The following is a description of a gene set: Human Gene Set: GOBP_CELL_CYCLE_G1_S_PHASE_TRANSITION studied in species Homo sapiens The cell cycle process by which a cell in G1 phase commits to S phase., and this is the list of marker genes: BTN2A2, PBRM1, RPS6KB1, CDKN2C, MLF1, TFDP3, ZNF324, DDRGK1, CUL2, SLFN11, ATP2B4, TRIM39 (NCBI Gene Id 56658), MYO16, RGCC, MIR372, CCNI2, PAGR1, MIR26A1, GPR132, ACVR1B, CUL4A, MTBP, CDKN2B, MIR15B, GSPT1, CTDSP2, MYB, TRIAP1 (TP53 regulated inhibitor of apoptosis 1), PLK2, CUL4B, FBXO7, MIR29A, INO80, MIR208A, PSME3, CCND1, RDX, EIF4EBP1, LSM11, CCND3, CDC7, CCNJ, SKP2, CPSF3, CCNO, WEE1, MAP3K11, EIF4G1, MIR29B1, MIR133A1, PRKDC (protein kinase, DNA-activated, catalytic subunit), BCL2, CCND2, GFI1B, RRM2, TREX1, TAF10, MIR520A, CDC34 (NCBI Gene Id 997), CDK2, CRNN, JADE1, PHF8, MIR519D, RASSF1, MIR362 (NCBI Gene Id 574030), SOX2 (NCBI Gene Id 6657), TAF1, SUSD2, AIF1, FAM107A, MIR638, BCL7C, MIR133B, PPP3CA, SMARCA4, DBF4, ECD, CCNA2, SMARCD2, RBL1, SASS6, CACNB4, LATS2, ANKRD17, CDK7, ID4, NANOGP8, ARID2, SDE2, CCNG2, RBL2, RFWD3, TMEM14B, MIR16-1, CCNB1, CDKN1B, SMARCB1, DPF3, EZH2, PRMT2, CACUL1, KIF14, CDK4, UBE2E2, DPF2, APPL2, MIR515-1, MN1, TRIM71, APPL1, MIR222, MIR221, CENPJ, ADAM17, RPS27L, CYP1A1, BRD7, TP63, CCNF, MIR30C2, PLK3, ACTB, MIR193A, RRM1, APC, MIR10A, CUL3, CDK10, PIM2, ZNF655, TP53, KLF11, CCNB3, CCNB2, CCNE1, TCIM, PLCB1, KHDRBS1, HINFP, CDK3, CDK6, CCNG1, LATS1, DACT1, CDK2AP2, CDKN3, MIR503, GLI1, ARID1B, MIR29C, SMARCD1, CRLF3, CCNI, CCNP, MYC, FAM83D, MIR214, DCUN1D3, GIGYF2, STXBP4, DLG1, EIF4E, AMBRA1, CTDSP1, KANK2, DGKZ, E2F3, SMARCC1, TMSB4X (thymosin beta 4 X-linked), ACVR1, STOX1, RPA2, USP26, SMARCD3, MEPCE, CTDSPL, PKD2, ACTL6B, TCF3, BCL7B, ADAMTS1, CCNJL, BID, CCNH, PTEN, CCNE2, MIR873, WAC, DDR2, CDC6, RCC1 (NCBI Gene Id 751867), KLF4, E2F7, PLRG1, BCL7A, ZC3H12D (NCBI Gene Id 387078), PAF1, E2F1, ACTL6A, CDKN2D, SENP2, ANXA1, CCL2, CAMK2A, RB1, IQGAP3, INHBA, AKT1, FBXO31, CDKN2A, MDM2, FBXW7, USP29, SMARCE1, CCNA1 (NCBI Gene Id 8900), MIR451A, MIR520H, DDX3X, STIL (NCBI Gene Id 6491), GPNMB, NPAT, PSME2, KCNA5, SPDYA, PTPN6, CDC25A, POLE, TBX2, RPTOR (NCBI Gene Id 654218), PKD1, ID2, APBB1, PLK5, MBLAC1, MNAT1, CUL1, PTENP1-AS, CDKN1A, SMARCA2, RHOU, CDC73, PLCG2, MIR892B, GPR15LG, TM4SF5, FGF10 (fibroblast growth factor 10), PPP6C, MIR15A, CUL5, USP37, ITGB1, FHL1, PSME1, PKP3, KMT2E, PIAS1, TERT, SMARCC2, PHF10, RBBP8, LSM10, ARID1A, DPF1, MUC1, BCAT1, MIR495, PPP2CA, TFDP1, MIR137, EGFR, CDK1